The following is a description of a gene set: Human Gene Set: GOBP_PROTEIN_O_LINKED_GLYCOSYLATION_VIA_THREONINE The glycosylation of protein via the O3 atom of peptidyl-threonine, forming O3-glycosyl-L-threonine; the most common forms are N-acetylgalactosaminyl, mannosyl, and galactosyl threonine. studied in species Homo sapiens, and this is the list of marker genes: GALNT4, EOGT, GALNT16, GALNTL6 (polypeptide N-acetylgalactosaminyltransferase like 6), GALNT11, GALNT3, GALNT1, GALNT13, GALNT6, GALNT2